Given this list of marker genes NR2F1, XRCC6, PHB1, TENM3, CDKN2B, SF3A1, GJB3, ZNF22, CRABP2, ACTR3 (NCBI Gene Id 10096), AGTR2, PCYT2, CCZ1, PCLAF, HSPA4, MGP, APCDD1, SLC35C2, UCK2, FHL1, NMT1, GRB2, FBN2, SLC3A2, RPL39L, GLRB, LBHD1, ZDHHC6, CARS1, MIR191, TSHB, RHOU, ACTN4, BMP6, CCN4, HSPA9, MYBL2, PRSS23, NARS1, PAG1, FARSB, TCF7, PPIH, BPGM, CH25H, PDGFA (platelet derived growth factor subunit A), GTF2IRD2B, EFNB2, DDX47, CRYGD, AOPEP, RUFY1, DBNL, ACLY, TMEM97, TMX2 (NCBI Gene Id 51075), RNF227, MAIP1, BUB1, CEACAM4, COPS5, MAPK12, FAP, FERMT2, WNT5A, RNF6 (NCBI Gene Id 6049), TNFAIP2, ARF3, IARS1, ZFTRAF1, LDLR, HSPB2, WNT10A, HOXD8, NSUN2, QNG1, NUPR1, C1QTNF3, MEF2C, DLK1, SIGLEC1, SERPING1, COL7A1, NDN, GBP2, MID1IP1, TRIB3, YARS1, NDE1, EMC6, NHERF1, RCL1, MTHFD2, DDIT3, PTPRF, ARX, FEN1, NOP56, GAS5, DDX18, TES, SDC2, KCNU1, SRPX, CD24, SQLE, SPP1, CPXM1, IGF1, ASNS, NNAT, B4GALNT1, ST13, ADORA2B, LAMA4, DBN1, DCTN5, here is a description of the gene set: Up-regulated in brown preadipocytes with IRS1 knockout vs wild type controls; the knockouts have severe defects in adipocyte differentiation. Human Gene Set: TSENG_IRS1_TARGETS_UP species: Mus musculus from publication Tseng YH, Butte AJ, Kokkotou E, Yechoor VK, Taniguchi CM, Kriauciunas KM, Cypess AM, Niinobe M, Yoshikawa K, Patti ME, Kahn CR (PMID 15895078) The insulin/IGF-1 (insulin-like growth factor 1) signalling pathway promotes adipocyte differentiation via complex signalling networks. Here, using microarray analysis of brown preadipocytes that are derived from wild-type and insulin receptor substrate (Irs) knockout animals that exhibit progressively impaired differentiation, we define genes/expressed-sequence tags whose expression in preadipocytes correlates with the ultimate ability of the cells to differentiate. Many of these genes, including preadipocyte factor-1 (Pref-1) and multiple members of the Wnt signalling pathway, are related to early adipogenic events. Necdin is also markedly increased in Irs knockout cells that cannot differentiate, and knockdown of necdin restores brown adipogenesis with downregulation of Pref-1 and Wnt10a expression. Insulin receptor substrate proteins regulate a necdin-E2F4 interaction that represses peroxisome-proliferator-activated receptor gamma (PPARgamma) transcription via a cyclic AMP response element binding protein (CREB)-dependent pathway. Together these define a key signalling network that is involved in brown preadipocyte determination.